The following is a description of a gene set: species: Mus musculus In base excision repair, an altered base is removed by a DNA glycosylase enzyme, followed by excision of the resulting sugar phosphate. The small gap left in the DNA helix is filled in by the sequential action of DNA polymerase and DNA ligase. Mouse Gene Set: GOBP_BASE_EXCISION_REPAIR, and this is the list of marker genes: Ogg1, Ung (uracil DNA glycosylase), Mpg, Tdg (thymine DNA glycosylase), Lig1, Hmga1b, Apex1, Rps3, Parp2, Dna2, Xpa, Nthl1, Fen1, Mutyh, Fam168a, Poll, Parp1, Smug1, Hmgb1, Pole, Ercc5, Usp47, Neil3, Rpa3, Neil1, Huwe1, Rpa1, Ercc6 (NCBI Gene Id 319955), Polg, Xrcc1, Hmga2, Neil2, Pold1, Polq, Wrn, Hmga1, Polb, Sirt6, Pcna, Tdg-ps, Apex2, Rpa2